Given this list of marker genes SYT1, ATP2A2, RAB3GAP1, RAB3A, CACNA1B, CDK5, PPP3CA, here is a description of the gene set: Any process that modulates the frequency, rate or extent of calcium ion-dependent exocytosis of neurotransmitter. studied in species Homo sapiens Human Gene Set: GOBP_REGULATION_OF_CALCIUM_ION_DEPENDENT_EXOCYTOSIS_OF_NEUROTRANSMITTER